Given this list of marker genes FGF20, GRM2, CHRNA6, PINK1, MECP2, CXCL12, SYT1, ADORA3, GNAT1, ADRA2A (NCBI Gene Id 92480), ADORA2A, GDNF, PRKN, HTR2A, ABAT, KCNA2 (NCBI Gene Id 3737), SYT11, ADRA2B, SDHD, OPRK1, NPY2R, DRD2, DTNBP1, ADRA2C, KCNB1, TGM2, GRK2, STX1A, GHSR, SLC18A2, SNCG, COMT (NCBI Gene Id 1312), CHRNB2, SNCA, KPNA4, P2RY1, VIP, CARTPT, CRH, CHGA, OXT, CHRNA4, GABBR1, SYT4, FFAR3, DRD3, here is a description of the gene set: The regulated release of catecholamines by a cell. The catecholamines are a group of physiologically important biogenic amines that possess a catechol (3,4-dihydroxyphenyl) nucleus and are derivatives of 3,4-dihydroxyphenylethylamine. Human Gene Set: GOBP_CATECHOLAMINE_SECRETION species: Homo sapiens